Given this list of marker genes Adamts9, Zeb2, Bloc1s6, Kitl, Bloc1s5, Bax, Bcl2 (NCBI Gene Id 98734), Adamts20, here is a description of the gene set: species: Mus musculus Any process that increases the frequency, rate or extent of the developmental process that results in the deposition of coloring matter in an organism. Mouse Gene Set: GOBP_POSITIVE_REGULATION_OF_DEVELOPMENTAL_PIGMENTATION